The following is a description of a gene set: An intracellular signaling cassette in which a small monomeric GTPase of the Cdc42 subfamily relays a signal. species: Homo sapiens Human Gene Set: GOBP_CDC42_PROTEIN_SIGNAL_TRANSDUCTION, and this is the list of marker genes: APOE, ABL1, TAX1BP3, ARHGEF16, RALBP1, RIT2, NTN1, CCR7, CCL19, NRP1, APOC3, APOA1, SHTN1, WAS, ABCA1